Given this list of marker genes Prkcd, Ripor1, Ehd1, Nutf2-ps1, Zdhhc2, Zic1, Ppm1a, Gsk3b, Hsp90aa1, Gper1, Nrde2 (nrde-2 necessary for RNA interference, domain containing), Caly, Tbc1d20, Mapk14, Prkaca, Tpr (NCBI Gene Id 74816), Vamp2, Oaz2, Pik3r2, Oaz1 (NCBI Gene Id 18245), Edem2, Pcm1, Sfn, Pla2g4e, Chp2, Smo, Khdrbs1, Anxa2, Sec16b, Mapk1 (mitogen-activated protein kinase 1), Numa1, Xpo4, Zc3h12a, Trim46, Camk4, Tnfrsf1a, Tmem30a, Hsp90ab1, Dhx9, Ncbp2, Cdk1, Actn2, Mecp2, Tmem30b, Rufy3, Nf2, Chrm1, Tardbp, Zfand1, Slc35d3, Ctdspl2 (CTD small phosphatase like 2), Scp2 (NCBI Gene Id 99990), Ergic3, Emd, Map2, Ehd2, Pik3r1, Gli3, Ran (RAN, member RAS oncogene family), Anp32b, Cdc42, Rab29, Cpsf6, Asph, Gas6, Ep300, Strit1, Edem1 (ER degradation enhancer, mannosidase alpha-like 1), Vps11, Sorl1 (NCBI Gene Id 72910), Efcab7, Prkd1, Tenm1, Tm9sf4, Rbm22, Akap5, Riok2, Lep, Dmap1, Ubr5, Mavs, Dctn1, Flna, Nutf2 (nuclear transport factor 2), Slc51b, Plk3, Brca1, Eif3e, Ifng, Pgap1, Msn, Pdcd5-ps, Uaca, Stx18, Jak2, Bcap31, Hyal2, Rdx, Mdm2 (transformed mouse 3T3 cell double minute 2), Commd1, Cdh1, Mtmr2, Dync1h1, Hcls1 (NCBI Gene Id 15163), Jup, Ptgs2 (NCBI Gene Id 19225), Ipo5, Pdcd5, Dab2, Rab21, Eipr1, Tek, Arf1, Abca12, Prpf4b, Atp2a1, Kif5b, Fez1, Ezr, Stk11, Ptpn23, Ywhae, Trim28, Hdac3, Wipf1, Zpr1, Ect2, Prkcq, Cep290, Rapgef3 (Rap guanine nucleotide exchange factor (GEF) 3), Kif20b, Oaz3, Kif3a, Tgfb1, B3gat3, Capn10, Spag5, Camk1 (NCBI Gene Id 52163), Nedd4, Shh, Bag3, Ldlrap1, Cd81, Ptpn5, Xbp1, Prr5l, Borcs5 (BLOC-1 related complex subunit 5), Pdcd10, Pcnt, Mlc1, Psen1, Il6, Ice1, Ptpn22, Sirt6, Cep131, here is a description of the gene set: Any process that activates or increases the frequency, rate or extent of the directed movement of substances within cells. species: Mus musculus Mouse Gene Set: GOBP_POSITIVE_REGULATION_OF_INTRACELLULAR_TRANSPORT